The following is a description of a gene set: species: Homo sapiens Any process that activates or increases the frequency, rate, or extent of an antimicrobial humoral response. Human Gene Set: GOBP_POSITIVE_REGULATION_OF_ANTIMICROBIAL_HUMORAL_RESPONSE, and this is the list of marker genes: ACOD1, IL17A, PGC, KLK5, IL17F, KLK3, KLK7